The following is a description of a gene set: Human Gene Set: GOBP_COMMON_BILE_DUCT_DEVELOPMENT studied in species Homo sapiens The progression of the common bile duct over time, from its formation to the mature structure. The common bile duct is formed from the joining of the common hepatic duct running from the liver, and the cystic duct running from the gallbladder. The common bile duct transports bile from the liver and gallbladder to the intestine., and this is the list of marker genes: NOTCH2 (NCBI Gene Id 55574), SOX9 (NCBI Gene Id 6662), SOX17, HES1, MKS1